The following is a description of a gene set: from publication Lee Y, Kawagoe R, Sasai K, Li Y, Russell HR, Curran T, McKinnon PJ (PMID 17452975) Genes down-regulated in medulloblastoma tumors from animals with inactivating mutations of one copy of PTCH1 or SUFU in conjunction with TP53 loss. Human Gene Set: LEE_TARGETS_OF_PTCH1_AND_SUFU_DN The Sonic Hedgehog (SHH) signaling pathway is indispensable for development, and functions to activate a transcriptional program modulated by the GLI transcription factors. Here, we report that loss of a regulator of the SHH pathway, Suppressor of Fused (Sufu), resulted in early embryonic lethality in the mouse similar to inactivation of another SHH regulator, Patched1 (Ptch1). In contrast to Ptch1+/- mice, Sufu+/- mice were not tumor prone. However, in conjunction with p53 loss, Sufu+/- animals developed tumors including medulloblastoma and rhabdomyosarcoma. Tumors present in Sufu+/-p53-/- animals resulted from Sufu loss of heterozygosity. Sufu+/-p53-/- medulloblastomas also expressed a signature gene expression profile typical of aberrant SHH signaling, including upregulation of N-myc, Sfrp1, Ptch2 and cyclin D1. Finally, the Smoothened inhibitor, hedgehog antagonist, did not block growth of tumors arising from Sufu inactivation. These data demonstrate that Sufu is essential for development and functions as a tumor suppressor. studied in species Mus musculus, and this is the list of marker genes: GJA1, RCAN2, NCAM1, ELMOD1, C11orf87, FNBP1, NTM, HMGCS1, MEG8, FAM241B, CAMK2D, ABLIM1, CA8, MASP1, NDRG4, SLC8A1, CDS1 (CDP-diacylglycerol synthase 1), CACNA1G, SLC13A3, ATP1B1, PPP1R3C, MAPRE2 (microtubule associated protein RP/EB family member 2), CKMT1B, CBLN1, SEMA3E, ASPH, SPOCK2, MAPRE3, SKOR1, KIF1A, MEG3, TMEM50B, PRKCG, KCNK1, GRM3, PCP2, SYT1, THY1, VAMP2 (NCBI Gene Id 6844), GUCY1A1, CNIH2, ATP2B2, DYNLT3, HK1, TSPAN17 (NCBI Gene Id 89852), NRIP3, NAPB, SLC32A1, LRP8, CSDC2 (cold shock domain containing C2), CEND1, ATP2A2, KIF5A, RAB4A (RAB4A, member RAS oncogene family), RORA, CALB1, RAB3A, CLSTN2, SLC4A10, PAK1, ITPKA, PENK, DCLK1, NRSN1, MAP4, GRIA1, PDXK, LYNX1, VSNL1, ALDH1L1, PREPL, CNP, KCND2, ZIC3, SLC1A6, NEFH, ITPR1, TRPC3, C1QTNF4, CHCHD10, GAD1, PTGDS, NRXN3, SEZ6L2, TSPAN2, PTPRR, PCSK1N